Given this list of marker genes Trex2, Rps3, Dclre1a, Rbbp8, Dclre1c, Aste1, Exd2, Pld4, Polq, Apex2, Mre11a, Pold1, Eme2, Ercc4, Eme1, Endov, N4bp2, Rad51c, Rexo2, Dffb, Gen1, Isg20, Dnase1, Dnase1l1, Bivm, Ercc1, C1qbp, Mus81, Tatdn1, Endog (NCBI Gene Id 13804), Aen, Aplf, Ercc5, Aptx, Mgme1, Dnase1l3, Slx1b, Dnase2a (deoxyribonuclease II alpha), Rad50, Zranb3, Ankle1, Meiob, Xrcc3, Exo5, Fan1, Pole, Dnase2b, Dna2 (NCBI Gene Id 327762), Apex1, Pld3, Exog, Rad1, Xrcc4, Polg, Xrcc1, Nme1, Rag1, Dclre1b, Dicer1, Setmar, Trex1, Ptbp1, Exo1, Dffa, Fen1, Dynll1, Rad9a, Dnase1l2, here is a description of the gene set: Catalysis of the hydrolysis of ester linkages within deoxyribonucleic acid. Mouse Gene Set: GOMF_DNA_NUCLEASE_ACTIVITY species: Mus musculus